Given this list of marker genes Sh3bgrl2, Cplx2, Glul, Stradb, Gpr176, Adra1a, Fbxl17, Wdr4, Ubap2l, Nfib, Kif5c, Setbp1, Ice2, Apoc3, Gm4847, Rbbp4, Srsf6 (serine and arginine-rich splicing factor 6), Prrc2b, Acsl1 (acyl-CoA synthetase long-chain family member 1), Ucn2, Ppp1r7, Ppm1n, Mtarc1, Lpcat3, BC061237, Srsf1, Ppm1d, Hsp90aa1, Arl13b, Plppr5, Tmtc2, Ss18, Skint4, Wdr91, Nrp1, Klhl14 (NCBI Gene Id 73999), Slc1a4, Gid8, Ube2k, Bach2, Arpc1a, Zpbp, Sfr1, Mtmr7, Clvs1, Scfd2 (Sec1 family domain containing 2), Chrd, Ssu72, Slc44a5, Gorasp2, 1700001F09Rik, Irf2, Zic4, Slc16a10, Gm10377, Lhx9, Aldoart1, Hnrnpa3, Kras, Mlxip, Tmem127, Slc46a2, Phox2b, Cltc, Aak1, Bbs4, Pm20d1, Klf11, Vip, Rora, Sema4c, Gm10375, Gm5800, Prox1, Ube2m, Ppm1b, Bnc2, Gdpd4, Rasgrp3, Rtn4, Vwa8, Adcyap1r1, Ikzf2, Ccnd2, Gopc, Klf6, Pcmtd1, Mrpl51, Trim66, Ei24, Arrdc4, Patl2, Wac, Dpf1, here is a description of the gene set: Genes predicted to be targets of miRBase v22 microRNA mmu_miR_6949_3p in miRDB v6.0 with MirTarget v4 prediction scores > 80 (high confidence targets). Mouse Gene Set: MIR_6949_3P species: Mus musculus from publication Chen Y, Wang X (PMID 31504780)